Given this list of marker genes Ppt2, Eif5a, Trim68, Lmod1, Ppp1r10, Septin3, Hspa13, Klhdc8a, Usp49, Aldh1b1, St3gal3, Tmx2, Gna13, Fam168a, Fst, Syne3, Rimkla, Pomt1, Pdzd4, Opn1sw, Zfp704, E2f1, Des, Castor2 (NCBI Gene Id 80909), Vash1, Uhrf2, Spag7, Krt84, Mtmr3, Fgfr3 (NCBI Gene Id 14184), Grhl3, Tifab, Klhdc4, Cdkn1c, Camkk1, Dusp7 (NCBI Gene Id 235584), Stk25, Rell2, Gjc3, Rel, Plxnc1, Lrrc41, Nat8l, Tnfaip2 (NCBI Gene Id 21928), here is a description of the gene set: from publication Chen Y, Wang X (PMID 31504780) Mouse Gene Set: MIR_6955_5P Genes predicted to be targets of miRBase v22 microRNA mmu_miR_6955_5p in miRDB v6.0 with MirTarget v4 prediction scores > 80 (high confidence targets). studied in species Mus musculus